The following is a description of a gene set: Human Gene Set: MIR3667_5P from publication Chen Y, Wang X (PMID 31504780) studied in species Homo sapiens Genes predicted to be targets of miRBase v22 microRNA hsa-miR-3667-5p in miRDB v6.0 with MirTarget v4 prediction scores > 80 (high confidence targets)., and this is the list of marker genes: CSTF3, RIC3, AKT3, ADAT2, CCT6B, CHN2, LCT, NEURL1B, CMTM6, SOX6, CAMK2D, KDM5D, APP (amyloid beta precursor protein), TWIST2, CDC6, RBFOX1, SLC35D1, ELAC1, NUP98, SPO11, PTPRK, GCNA, SNAPC3, ZNF718, EMC4 (ER membrane protein complex subunit 4), PPP2R2B, PTCHD1, CBX3 (chromobox 3), ZNF521, SP4, PLEKHB2, CLDN12, MFSD14A, ANKRD28, ASB13, NRIP1, DIRAS2, VPS72 (NCBI Gene Id 6944), SLC22A3, ACACA, KCNN3, MYCBP, ATP2B1, FRRS1 (NCBI Gene Id 391059), SEMA3C, C10orf67 (NCBI Gene Id 387642), YBX1 (Y-box binding protein 1), HEATR4, OSGEPL1, COQ2, EYA4, BTBD9, HOXD10, EPB41L1, PNLIPRP3, INSIG1, STON2